The following is a description of a gene set: species: Homo sapiens Human Gene Set: GOBP_POSITIVE_REGULATION_OF_CHEMOKINE_C_C_MOTIF_LIGAND_5_PRODUCTION Any process that activates or increases the frequency, rate, or extent of production of chemokine (C-C motif) ligand 5., and this is the list of marker genes: ADCYAP1, DEFB124, DDX3X, TRPV4, MAVS, MCOLN2, TICAM2 (NCBI Gene Id 353376)